Given this list of marker genes AP2B1, AP2M1, PRKCA, DVL2, AP2S1, WNT5A, AP2A1 (NCBI Gene Id 92649), CLTB, FZD4, CLTA, ARRB2, PRKCG, AP2A2, CLTC, PRKCB, here is a description of the gene set: WNT5A induces internalization of FZD4 in a manner that depends upon PKC-mediated phosphorylation of DVL2. Uptake of FZD4 appears to occur in a clathrin, AP-2 and ARBB2-dependent mannner. Reactome Pathway: WNT5A-dependent internalization of FZD4 part of: PCP/CE pathway studied in species Homo sapiens